The following is a description of a gene set: Reactome Pathway: Plasmalogen biosynthesis part of: Wax and plasmalogen biosynthesis studied in species Homo sapiens 1-Acylglycerol-3-phosphate is synthesized from dihydroxyacetone phosphate, an acyl CoA molecule and NADPH + H+ in four reactions catalyzed by peroxisomal enzymes, either in the matrix of the organelle or associated with its membrane. These reactions are annotated here for palmityl (C16:0) CoA. In a series of less well-characterized reactions in the cytosol and endoplasmic reticulum, these molecules are converted to ether lipids (plasmalogens). The functions of plasmalogens are not well understood. They are an abundant subclass of phospholipids, however, and defects in their metabolism are associated with serious human disease (de Vet et al. 1999; Nagan and Zoeller 2001)., and this is the list of marker genes: AGPS, GNPAT, DHRS7B